The following is a description of a gene set: Mouse Gene Set: GOBP_POSITIVE_REGULATION_OF_MACROAUTOPHAGY Any process, such as recognition of nutrient depletion, that activates or increases the rate of macroautophagy to bring cytosolic macromolecules to the vacuole/lysosome for degradation. species: Mus musculus, and this is the list of marker genes: Ikbkg, Map3k7, Hmox1, Ralb, Tlr2, Sptlc1, Snx4, Trim32, Calcoco2, Csnk2a1, Vdac1, Scoc, Fyco1, Dele1, Snx30, Sting1, Sesn2, Rab3gap2, Cdc37, Bnip3, Igtp, Wdr24, Tsc2, Supt5, Sh3glb1 (SH3-domain GRB2-like B1 (endophilin)), Lrsam1, Pip4k2c, Cdk5rap3, Il4, Tsc1, Pafah1b2, Hk2, Ube2a (ubiquitin-conjugating enzyme E2A), Moap1, Tom1, Ddrgk1, Kat5, Bnip3l, Wac, Hif1a, C9orf72, Wipi1, Bag3, Dcn, Gnai3, Irgm1, Tbk1, Epm2a, Stub1, Sptlc2, Sesn1 (sestrin 1), Snx7 (sorting nexin 7), Slc25a4, Rab3gap1, Nod1, Irgm2, Ulk1, Fbxo7, Optn (NCBI Gene Id 71648), Ambra1, Htt, Cers1, Vps13d, Rufy4, Trim13, Slc25a5, Hdac6, Pim2, Clec16a, Pip4k2a, Hspb8, Snx18, Nod2, Ufl1, Eif2ak1, Mul1, Sesn3, Elapor1, Atp5if1, Atg2a, Rnf31, Pip4k2b, Zdhhc19, Adrb2, Becn1, Rab12 (NCBI Gene Id 98056), Kdr (kinase insert domain protein receptor), Prkn, Ripk2, Larp1, Gba1, Smcr8, Tomm7, Gpsm1, Sirt1, Pink1, Wdr45, Mapk3, Huwe1